The following is a description of a gene set: TGF-beta receptor 1 (TGFBR1) loss-of-function is a less frequent mechanism for inactivation of TGF-beta signaling in cancer compared to SMAD4 and TGFBR2 inactivation. Genomic deletion of TGFBR1 locus has been reported in pancreatic cancer, biliary duct cancer and lymphoma, while loss-of-function mutations have been reported in breast and ovarian cancer, metastatic head-and-neck cancer, and in Ferguson-Smith tumors (multiple self-healing squamous epithelioma - MSSE). Loss-of-function mutations mainly affect the ligand-binding extracellular domain of TGFBR1 and the kinase domain of TGFBR1. In the mouse model of colorectal cancer, Tgfbr1 haploinsufficiency cooperates with Apc haploinsufficiency in the development of intestinal tumors. part of: Signaling by TGF-beta Receptor Complex in Cancer Reactome Pathway: Loss of Function of TGFBR1 in Cancer species: Homo sapiens, and this is the list of marker genes: SMAD3, SMAD2, FKBP1A, TGFB1, TGFBR2, TGFBR1, ZFYVE9